Given this list of marker genes RANBP6, ST6GALNAC2 (NCBI Gene Id 6488), CCDC185, TNFRSF13B, RADIL, PHF1, FOXA2, TMCO5A, FAM162B, GRIP1, VSIR, MMP19, DEPTOR, NELL2, CCDC137, DAPL1 (death associated protein like 1), PARS2, CACNA1C, VMAC, SNAP29, PTHLH, ZNF688, TPD52, ANG, HYCC2, RNF125, LPAR6, TMTC4 (NCBI Gene Id 94896), SEPTIN4, NEDD4L, SAMD4A, SLC35F4, PROP1, MYO5A, CHP1, UBE2H, ADORA3, TAF1, ANKUB1, COPS2, RITA1, PPT1, CARF, COG6, LMX1B, TK2, DUOXA1, SLC25A53, GABRB2, NLRP14, LPIN1, CXCL13, RCL1, PKNOX2, VEGFC, AK5, PIK3CG (phosphatidylinositol-4,5-bisphosphate 3-kinase catalytic subunit gamma), IFT46, ATP8A1, IGF2, SLC35D3, TLR7, NT5M, CD53, PDILT, DPM3, TMEM71, OAZ2, CD93, ZYX, CSAD, FCER1G, RXRB, POLK, PLXNC1, EME2, CPA6, HELB, SYNE3, SYNRG, ZFYVE1, TMEM107, IGF1R, SIGIRR, S1PR1, KCNH8, PTOV1, SLC23A2, PRDX3, SETDB1, PCNX4, PTAR1, GALNT2, NMBR, VSIG10, CDK17, DENND1B, BIK, CDK19, R3HCC1, TMED7, GALNT4, SHPK, NCF2, H3C4, ING2, CD99L2, HIC2, SCN9A, CROT, FAM110B, AKAP10, STEEP1, CATSPERG, AGO4, STAT5B, SYP, HLA-DMA, MED26, MAP4K1, WDR45B, SLC13A3 (solute carrier family 13 member 3), VWC2 (von Willebrand factor C domain containing 2), UBFD1, RBM11, FLI1, CDH22, DYM, IGFBP4, IL16, ZBTB16, KIAA0586, UQCRC1, NKX2-1, GPALPP1, B3GLCT, KRT84, NET1, FAM91A1, FHAD1, IRF4, DMRT1, ULK2, PRSS41, NEIL1, CCDC47, WDR18, CD28, RBL2, RGS14, CCSER2, NLRX1, ZNF668, CHRM1, GLIPR2, KCNJ14 (potassium inwardly rectifying channel subfamily J member 14), EXD2, RYR3, LRP6, LMO2, TKTL2, VAV3, PHF13, H3C7, YPEL4, WDR89, ANKRD35, MTARC2, KANSL2, CNKSR3, APOF, LRRC4, ZNF324B, POMT1, CNN2, RAMP1, C1orf21, AFM (NCBI Gene Id 173), PCMTD1, RANBP17, B3GNT2, NIPAL1, AMFR, FBXL8, KRTAP21-1, SLC8B1, HRH4, BOLL, APPL2, DNAH11, ABCB10, TCF15, SLC25A51, ZNF512B, SUPT3H, LRRC41, CYBC1, PIEZO2, MACO1, here is a description of the gene set: Human Gene Set: GSE22282_HYPOXIA_VS_NORMOXIA_MYELOID_DC_DN Dendritic cells (DCs) are professional antigen-presenting cells whose activity is intrinsically linked to the microenvironment. Hypoxia is a condition of low oxygen tension occurring in inflammatory tissues that creates a special microenvironment conditioning cell physiology. We studied the effects of hypoxia on the differentiation of human monocytes into DCs and maturation into mature DCs. Mature DCs were differentiated in vitro from human monocytes under normoxic or hypoxic conditions and the gene expression profile was determined. Genes down-regulated in myeloid dendritic cells: hypoxia versus normoxia. studied in species Homo sapiens from publication Bosco MC, Pierobon D, Blengio F, Raggi F, Vanni C, Gattorno M, Eva A, Novelli F, Cappello P, Giovarelli M, Varesio L (PMID 21148811)